The following is a description of a gene set: Mouse Gene Set: CUI_TCF21_TARGETS_2_DN studied in species Mus musculus from publication Cui S, Li C, Ema M, Weinstein J, Quaggin SE (PMID 16207825) Mouse mutations have provided tremendous insights into the molecular basis of renal and glomerular development. However, genes often play important roles during multiple stages of nephrogenesis, making it difficult to determine the role of a gene in a specific cell lineage such as the podocyte. Conditional gene targeting and chimeric analysis are two possible approaches to dissect the function of genes in specific cell populations. However, these are labor-intensive and costly and require the generation, validation, and analysis of additional transgenic lines. For overcoming these shortcomings and, specifically, for studying the role of gene function in developing glomeruli, a technique to isolate and purify glomeruli from murine embryos was developed. Combined with gene expression profiling, this method was used to identify differentially expressed genes in glomeruli from Pod1 knockout (KO) mice that die in the perinatal period with multiple renal defects. Glomeruli from early developing stages (late S-shape/early capillary loop) onward can be isolated successfully from wild-type and KO kidneys at 18.5 d postcoitus, and RNA can readily be obtained and used for genome-wide microarray analysis. With this approach, genes that are differently expressed between glomeruli from Pod1 KO and wild-type mice were identified, including a four-fold reduction of alpha 8 integrin mRNA in glomeruli from Pod1 KO mice that was confirmed by immunostaining. This procedure may be adapted to any transgenic strain, providing a rapid and efficient method to dissect the function of specific genes in glomerular development. All significantly down-regulated genes in kidney glomeruli isolated from TCF21 knockout mice., and this is the list of marker genes: Cavin2, Coq10b, Nid1, Lgalsl (galectin like), Yipf4, Zfp185, Pdlim2, Wsb2, Gpd2, Ptger4, Gja3, Grm7, Emcn, B3galt2, Gimap1, Cdc14a, Selenot (NCBI Gene Id 70512), Pag1, Aif1l, Abca5, Scn7a (sodium channel, voltage-gated, type VII, alpha), Tnfrsf11b, Itgb8, Ppp1r13b, Mast4, Ifi35, Tubb2a, Cbl, Lrrfip1, Sacm1l, Gnb1, Arrb1, Nectin3, Arhgap24, Fgd5, Osbpl5, Tmem64, Lmbrd1, Nfil3, Tasor, Stxbp3, Per2, Sgms1, Fbxo3, Rerg (RAS-like, estrogen-regulated, growth-inhibitor), Slc36a4 (solute carrier family 36 (proton/amino acid symporter), member 4), Taok1, Osmr, Snapc3, Armcx3, Dcaf5, Rcan1, Ino80d, Tex2, Atp10a, Dtna, Btnl9, Lyst, Rbpms (RNA binding protein gene with multiple splicing), Ube2v2, Adgrl3, Rnf11, Ginm1, Sorbs1, Hipk3, Rnft1, Clock, Trpc1 (NCBI Gene Id 22063), Slc38a9, Arhgap28, Hip1, Phf20l1, Zfp518a, Vps54, Notch4, Sema3b, Pde4b, Rock1, Zhx1, Fermt2 (NCBI Gene Id 218952), Ebf1, H2ac25, Akirin1, Fam13c, Cbfa2t3, Araf, Cttnbp2, Prkaa1, Vim, Ncoa4, Ppp1r2, Ccnb1ip1, Col25a1, Zdhhc14, Cav2, Dleu2, Kif1b, Arid4a, Mgll, Kmt2c, Parva, Cdc42bpg, Itpkb, Ankrd29, H1f2, Colec12, Tmcc2, Itga4, Acer2, Il2rg, Mbnl2, Homer1, Phlpp1, Apbb2, Pde2a, Zfp729a, Irf2bp2, Serinc3, Map3k3, Ak1, Sncaip, Zfyve16, Cyyr1, Dynlt3, Zeb2, Msrb3, Atxn7l1, Degs1, Mmp23, Rgs2, Ctss (NCBI Gene Id 13040), Hsdl2, Usp42, Dipk2a, Sntb1, Trp53inp1, Snrk, Nopchap1, St6galnac3, Plce1, Gyg1, Slitrk6, Dync1li2, Elf1, Dnajb4, H6pd, H2-T23, Tcp11l2, Arhgap26, Atxn7, Ppip5k2, Vsig10, Nsf, Rictor, Arl13b, Rapgef2, Dst, H2bc4, Acap2, Adgrf5, Camk2d, Tlr4, Hspa1a, Shroom2, Usp12, Dennd2b, Cyp4b1, Phf20, Dock5, Metrnl, Prr15, Luc7l2, Synpo, Arfgef3, Fryl, Sema3g, Galnt10, Lmo7, Sox7, Gsn, Kank1, Secisbp2l, Nlk, Vps37a, Slc12a1, Gpr146, Tenm2, Ggct, Ing3, Agtr1a, B3gnt2, Ackr3, Ap5m1, Calm1, H3c14, Stk3, Cebpb, Arl8b, Ildr2, Dnajb14, Mospd2, Rab6b, Cables1, Hopx, Gadd45a, Kctd12b, Iqgap2, Dkk2, Bicd2, Pdp1, Erg, Pcdh12, Gm11772, H3c15, Fabp4, Tbc1d1, Anxa1, Cdh5, Frmd6, Jarid2, Pbx2, Nadk2, E2f5, Frk, Natd1, Cdc73, Parp14, Gimap8, Arhgap31, Pard6b, Tecpr1, Ripor2, Rapgef3, Fndc3a (NCBI Gene Id 76636), Chpt1, Lnpep, Acbd5, Cdc42ep3, Glcci1, Loxl2, Tspan12, Col4a4, Il10rb, Ago4, Rps6ka5, Ttc14, Nt5e, Uaca, Plat, Nrros, Ccrl2, Hey2, Rassf10, Ldb2, Med13, Tns2, Emc7, Rnf6, Cdkl2, Pcdh17, Ctla2a, Qki, Hecw2, Usp25, Klf3, Hsp90aa1, Klf4, Ncor1, Nphs2, Rapgef5, Rin2, Slc48a1, Cyp20a1, Jcad, Fam135a, Tmcc3, Tgfbr3, Itga8, Tmem150c, Rreb1, Trim12c, Tada2b, Tmed5, Calcrl, Slfn5, Usp46, Tcf25, Yod1 (NCBI Gene Id 76190), Lrba, Rasl11a, Zfr, Col12a1, Ldah, Serinc1, Lims1, Ehd4, Cep85l, Rras2, Shroom3, Heatr5b, Tbc1d12, Pank3, Sgpp1, Cxcl2, Hspa1b, Heatr5a, Jade1, Znrf2, Trak2, Scd2, Mapt, Adamts16, Tor1aip2, Coro1a, Ccn2, Zbtb44, Cybb, Kirrel1, Dnajb6, Macf1, Tmem65, Eml1, Pura, Kcnk6, Pde4dip (NCBI Gene Id 97109), Glrx2, Mtmr2, Mgat5, Igip, Kdm6a, Frs2, Gprin3, Tent5a, Bvht, Nsmaf (neutral sphingomyelinase (N-SMase) activation associated factor), Sox17, Myct1, Tnfaip8, Csnk1g3, Cxcr4, Rabgap1l, Plpp1, Vgll3, Asb15, Mtcl1, Ehd3, Adgrl4, Art3, Col4a5, Itga2, Umod, Stat1, Optn, Stard8, Lrmda, Clec1a, Rora, Sh3glb1, Mtmr6, Irs1, Kdm7a, Ephb1, Arhgef18, Nxt2, Eaf1, Pggt1b, Tanc1, Pum2, Clec4a3, Ifi204, Irgm2, Kank4, Fgd4, Acox1, Timp3, Hivep2, Zbtb8a, Tmem33, Snap23, Gulp1, Arhgap5, Tacc1, Rdh9, Slc12a2, Hivep1, Kif5b, Jam2, Ctdspl, Rcan2, Plpp3 (phospholipid phosphatase 3), Fam174a, Agfg1, Strn, St3gal6, Ppm1k, Lyz2, Ednrb, Nbeal1, Btbd3, Tmem30a, Cflar, Plscr1 (phospholipid scramblase 1), Clic5, Dennd11, Med23, Il6st, Lpp, Dstyk, Zfp758, Vegfa, Myo10, Arhgap29, Thbd, Scoc (short coiled-coil protein), Lipa, Mertk, Vasn, Prkg1, Ikzf5, Mtm1, Cfap68 (cilia and flagella associated protein 68), Icam2, Edem3 (ER degradation enhancer, mannosidase alpha-like 3, NCBI Gene Id 66967), Slco2a1, Plekhg1 (NCBI Gene Id 52522), Tob1, Fam43a, Vstm4, Slc35a5, Adcy1, Epn2, Lpar4, Dennd6a, Btaf1, Lpin2, Adam9, Mmrn2 (NCBI Gene Id 239033), Garre1, Ebag9, Tmem9b, Otud7b, Bbx, Dock4, Lypla1, Tbx3, Thbs1, Myadm, Anxa4, 2310030G06Rik, Sema5a, Mafb, Gopc, Rap1a, Egf, Ecpas, Sirpa, Pon2, Thap2, Dpp4, Lmx1b, Tiparp, Afap1l2, Man1a (NCBI Gene Id 17155), St8sia4, Fut11, Esco1, Mblac2, Spred2, Cpne8 (NCBI Gene Id 70271), Serpini1 (serine (or cysteine) peptidase inhibitor, clade I, member 1), Nid2, Samd4, Ctla2b, Wwc2, Crebbp, Mme, Ro60, Fam76a, Fli1, Entpd7, C1galt1c1, Rnf13, Usp33, Trip11, Pros1, Polb, Prkch, Myof, Exoc8 (exocyst complex component 8), Noct, Card10, A630072M18Rik, Vcl, Cpeb2, Kdm4c, Zfx, P2rx4, Arhgap17, Cyria, Sos2, Mcl1, Mpp3, Bmi1 (Bmi1 polycomb ring finger oncogene), Ids, Slk, Trim30a, Sh2b3 (NCBI Gene Id 16923), Adgre4, Ifi202b, Cpeb4, Mindy2 (NCBI Gene Id 235461), Rap1b, Dcdc2a, Tm4sf1, Neat1 (nuclear paraspeckle assembly transcript 1 (non-protein coding)), Hagh, Pard3b, Rbms1, Klhl5, C630043F03Rik, Ptprj, Clip1, Krt7, Inf2, Atg10, Mcf2, Gabra4, Tut7, Gtf2a1, Sdc2, Clca3a1, Sec11c, Cited2, Crim1, Pld1, Pcolce, Ppp4r3b, Jak1, Avpr1a, Crk, Krit1, Ap4e1, Fry, Zfp52, Zbtb4, Trib2, Shisa3, Arvcf, Mmd, Hs3st3b1, Atp7a, Tmem26, Itgb5, Dmxl1, Tspan2, Mtus1, Tlr3, Cd36, Itsn2, Tgfbr2, Magi2, Rtn4rl1, Ctbs, Zc3hav1, Ssbp2 (NCBI Gene Id 76496), Prdm1, Slc17a5, Bmpr1a, Zfp319, Tcf21, Wipf3, Cyrib, Ptar1, Ptprg, Adgra2, Lysmd3, Nes, Mndal, Zfp948, Rfk, Usp9x, Prkca, Ptprb, Eeig1, Col4a3, Cavin1, Tcim, Slc12a6, Osbpl8, Amy1, Dusp6, Tmc7, Sgk3, Cd55, Amotl1, Tpm1, Dach1, Mir22hg, Golga3, Fam174b, Hhex, Adm, Endod1, Hycc2, Syt17, Mprip, Npl, Plxdc2 (plexin domain containing 2), Map3k20, Tmbim1, Bace1, Nfkbia, Sh3bp5, Ep300, Fam241a, Dgkh, 1600012H06Rik, Dbt, Cblb (NCBI Gene Id 208650), Chmp1b, Ahnak, Inpp4a, Lasp1, Top1mt, Abi3, Lztfl1, Ttll7, Itsn1, Ripor1, Foxc1, Atp8b1, Ptpro, Armc8, Spire1, Sgip1, Epas1, Ypel5, Nedd9, Stag2 (NCBI Gene Id 78442), Prex2, Slc33a1, Sowahc, Gata3, Purb, Tmod3, Myo6, Gpc1, Slc38a4, Dsp, Myom2, Malt1, Ell2, Gmds, Celf2, Rab3gap2, Efnb2, Slain2, Lifr, Lmo2, Crebzf, Vps13a, Smim7, Rnpc3, Cryab, Foxc2, Vangl1, Tmem204, Speg, Pik3ca, Setd7, Rbbp6, Hs3st6, Chac2, Sfmbt1, Pdgfb, Daam2, Psd3, Arrdc3, Acsl4, Rasa2, Pcmtd2, Synj2bp, Cd59a, Plscr2, Gvin1, Peli2, Eif2s3x, Zbtb7c, Pde10a, Tceanc2, Ppp1r16b, Dubr, Nebl, Ifrd1, Diaph2, Kng1, Ddn, Dusp3, Gucy1a1, 4930503L19Rik (NCBI Gene Id 74795), Pakap, Oip5os1, Cdyl, Wdfy1, Ptprv, Ube2q2, Serpinb6b, Ash1l, Exoc3l2, Mark1, Zbtb46, Atg4a-ps, Csgalnact2, Serinc5, She, Myo1e, Myo18a, Pcmtd1, Fndc3b, Mbnl3, Tspan5, Myzap, Ulk2, Adgre5, Gab2, Plcl1, 9930012K11Rik, Cdkn1c, Tnfaip3, Micu1, Tle4, C1qtnf7, Ugp2, Prx, Sgk1, Gimap4, Txnip, Gem, Fyn, Ccdc82, Arhgef16, Myo1d, Hlx, Rnf103, Slc27a3, Klk1, Thsd7a, Cd47, Abcb1a, Trim23, Dpysl2, Rimoc1, Schip1, Sp2, Flt1, Tspan8, Tdrp, Ralb, P3h2, Tmem106b, Grk5, Arnt, Ubr3 (ubiquitin protein ligase E3 component n-recognin 3), Srgn, Mbd5, Riok3, Lin54, Arap2, Sh3bgrl2, Pfkfb3 (6-phosphofructo-2-kinase/fructose-2,6-biphosphatase 3), Lemd3, Mcc, Arhgef26, Rasgrp3, Rilpl1 (NCBI Gene Id 76185), Ankrd33b, Palld, Clec14a, Nck2, Plscr4, Ccdc126, Parp12, Cast, Cemip2, H3f3b, Sh2d4a, Zbtb38 (zinc finger and BTB domain containing 38), Kbtbd11, 4921524J17Rik, Foxn2, Cd38, Iqsec1, Fam120a (NCBI Gene Id 218236), Tek, Ccpg1, Slc2a12, Cers6, Lrrc28, Ablim3, Il13ra1, Kank3, Zfp715, Csgalnact1, Galc, Ntn4, Mkrn1 (makorin, ring finger protein, 1), Nostrin, Samd8, Son, Enpp4, Rhpn1, Sptlc2, Arhgef15, Snx13, Tmtc1, Vamp5, Htra1, Ptprc, Myo1b, Sema3e, Fmnl2, Npr3, Pitpnc1, Itprid2, Map3k2, Wwtr1 (NCBI Gene Id 97064), Ptpn12, Myo1c (myosin IC), Ublcp1, Retreg1, Zfp120, Itgb1, Pgm2, Slc2a3, Adamts5, App, Kitl, Calm2, Atp2a3, Lats2, Tpp1, Lipo3, Plod2, Ranbp9, Rmdn1, Med12l, Rc3h2, Arid5b, Efnb1, Parp4, Yes1, Rassf9, Sulf2, Itga9, Gimap6, Pals1, Nherf2, Mef2c, Vma21, Spop, Armcx1, Lrch1, Ergic2, Hspa12a, Rapgef4, Ets1, Mtss1, Foxp2